The following is a description of a gene set: Genes predicted to be targets of miRBase v22 microRNA hsa-miR-34a-3p in miRDB v6.0 with MirTarget v4 prediction scores > 80 (high confidence targets). from publication Chen Y, Wang X (PMID 31504780) studied in species Homo sapiens Human Gene Set: MIR34A_3P, and this is the list of marker genes: SELENOI, ANTXR2, ZNF480, PARP16, EHMT1, G3BP2, RUNX1, RMI1, ZC3H15, SNX4, ARHGEF35, YAP1, ZNF407, CERS6, SUMO1, SCRN3, NMT2, RNPEP, HDAC2, DDX27, SCYL2, RAB3IP (NCBI Gene Id 64325), TACC2, PHF6, WDR72, ADSS2, NTRK2, TET1, PRSS12, SPX (NCBI Gene Id 80763), ECHS1, RNF44, TMEM74, PDCD6IP, RFFL, KDM5B, APOBEC4, TCAIM, PCDH19, PTAR1, ADGRF4, GALNT1, PAXBP1, SLC22A5, CADM1, DEUP1, USP37, RNF135, ZHX1, UQCC1, GORAB, CAB39, NSD1, HSDL1, MAP3K4, TNF, SH3GLB1, MSR1, GPN1, EIF3CL, MIEF1, KIDINS220 (NCBI Gene Id 57498), DYRK1A, SHCBP1, XRN2, DEPDC5, MRC1, LRP2, EIF3C, TMEM176B, PALLD, ABHD10